Given this list of marker genes Noc2l, Pdcd1, Tsc22d3, Bcl2a1a, Blm, Cd27, Slc39a10, Mir19b-1, Mir93, St3gal1, Cd44, Il7r, Bcl11b, Mir18b, Bcl2, Tnfrsf4, Mir106a, Irs2, Mir19b-2, Pip, Hsh2d, Kifap3, Serpinb9 (NCBI Gene Id 20723), Mir92-2, Mir106b, Bcl10, Gpam, Ccl5, Bcl3, Il3 (NCBI Gene Id 16187), Vhl, Mif, Tnfsf4, Jak3, Prkcq, Foxp1, Mir92-1, Slc46a2, Bmp4, Rorc, Ptcra, Fcmr (Fc fragment of IgM receptor), Ada, Rag1, Ido1, Efna1, Ormdl3, Mir25, Arg2, Hif1a (NCBI Gene Id 15251), Cd74, Fadd, Dock8, Pnp, Mir363, Mir20b, Aurkb, Il2, here is a description of the gene set: Any process that stops, prevents, or reduces the frequency, rate or extent of lymphocyte death by apoptotic process. Mouse Gene Set: GOBP_NEGATIVE_REGULATION_OF_LYMPHOCYTE_APOPTOTIC_PROCESS species: Mus musculus